The following is a description of a gene set: studied in species Homo sapiens An abnormality of the intestine in which part of the intestine invaginates (telescopes) into another part of the intestine. Human Gene Set: HP_INTUSSUSCEPTION Intussusception, and this is the list of marker genes: STAT1, GREM1, SMAD4, STK11, PTEN, PDGFRA, ARID1B, EFEMP2, BMPR1A, UNC45A